The following is a description of a gene set: To obtain region- and disease-specific transcription profiles of human myocardial tissue, we explored mRNA expression from all four chambers of eight explanted failing, and five non-failing hearts using high-density oligonucleotide arrays (Affymetrix U95Av2). We performed pair-wise comparisons of gene expression in the categories (1) atria versus ventricles, (2) disease-regulated genes in atria and (3) disease-regulated genes in ventricles. In the 51 heart samples examined, genes showed divergent distribution between atria and ventricles (genes with higher expression in atria, genes with higher expression in ventricles). Two hundred and eighty-eight genes were differentially expressed in failing myocardium compared to non-failing hearts (genes regulated in atria and ventricles, 172 regulated in atria only, genes regulated in ventricles only). For disease-regulated genes, down-regulation was 4.5-times more common than up-regulation. Functional classification according to Gene Ontology identified specific biological patterns for differentially expressed genes. Eleven genes were validated by RT-PCR showing a good correlation with the microarray data. Our goal was to determine a gene expression fingerprint of the heart, accounting for region- and disease-specific aspects. Recognizing common gene expression patterns in heart failure will significantly contribute to the understanding of heart failure and may eventually lead to the development of pathway-specific therapies. Human Gene Set: KAAB_HEART_ATRIUM_VS_VENTRICLE_UP Genes up-regulated in the atria of healthy hearts, compared to venticles. from publication Kääb S, Barth AS, Margerie D, Dugas M, Gebauer M, Zwermann L, Merk S, Pfeufer A, Steinmeyer K, Bleich M, Kreuzer E, Steinbeck G, Näbauer M (PMID 15103417) studied in species Homo sapiens, and this is the list of marker genes: AGTR1, TRIP6, TIMP3, PTH1R, GRIN2C, ALDH1A2 (NCBI Gene Id 8854), PTGIS, SRSF8, ATM, CDC123, GJA5, EDNRA, NUPR1, ALOX12, TGFB1I1, MAP1B, VCAN, PLA2G2A, TBX5, FBLN2, QSOX1, PIP4K2B, EEF1A1, CHGB, FRMD4B, TUBB2A, ZNF271P, CD81, CSRP1, RALYL, LILRA4, ROR2, PRSS23, MYH6, DDR1, GRB2, ADORA1, CDK14, FGL2, DYRK2, NRTN, FEV, AKR1A1, KCNK1, VSNL1, MDK, MICAL2, POLD4, NALF2, PAM, TGFBR3, GPRASP1, CACNA2D2, EZH2, FGFR2, ARB2A, ERBB4, PLP1, AFAP1, EPHB2, MYBPC1, CALR, HEG1, EPS8, NDRG1 (N-myc downstream regulated 1), PBXIP1, FLRT2, LSM12, AEBP1, SOD3, EPB41L3, KHSRP, SMARCD2, SLC39A8, MAL, RELN, EPB41L1, NR2F2, ETV5, PRUNE2, MYLK, MYL6, ID4, RTN4, RPSA, NMNAT2, BTG1, CACNA1B, OS9, ADM, EXOSC2, RAB33A, GNB5, AGPAT1, CCN2, NME2, VASH1, F10, SURF2, DSC1, RPL3, BASP1, STAT4 (NCBI Gene Id 6775), SPOCK1, NUCB1, SMAD7, TAGLN, CD63, ME1, CD47, ID2, PTOV1, EPHA4, CDO1, RARRES2, XYLT1, CRIP1, MYL7, CPE, SLIT3, KCNJ3, CHRNE, PRELP, CHL1, ACTA2, PLK1, TGFB1, INPP1, RABGAP1L, LRRN3, CREB3L2, KCNK3, SLC9A1, UNC5B, S100A13, MYL4, MAGED2, KAZN, VAMP5, KCTD17, FMOD, FAM114A1, CYB561D2, PDE8B, MIPEP, RPS2, NSF, C1R (NCBI Gene Id 791254), SGCE, CELSR2, PLXNB2, MAGED1, KDELR2, PPIB, ITSN1, COL2A1, HYOU1, PLOD3, TMEM106C, ZFP36L2, CITED1, NR2F1, ABCC8, FEZ1, PRAF2, IL1RL1, TPGS2, CCDC85B (coiled-coil domain containing 85B), SLC22A18, NOMO1 (NODAL modulator 1), RBP1, PRDX1, TOR1A, BAD, SAT1, SLN, ERGIC3, WASHC2C, MGAT5, DAP, ACTN1, DAPK2, CFH, GRN, ENO2, DESI1, CHRDL1, STAT5B, ZNF365, PLCB1, MR1, SYNPO, PLA2G5, AUTS2, CADPS, GNAO1, NPPA, SERPINB8, BAMBI, CTSF, DPYSL3, TNK2, VAT1, ERBB2, BTG3, CCN5, EFEMP1, TSPAN7, NPPB, TAGLN2, AKR1C1, PARM1, ASXL1, TULP3, IGFBP6, USP11, CCL14, TRPC1, NTRK2, TNFSF13, NR0B2, PDE4B, SLC11A2, PML, TMED3, MYH11, SFRP1, KCNA5, NEB, GSE1, NAP1L1, DHODH, CIB2, DPT, ZNF208, JADE2, GPX3, GAS1, DDR2, PRKCD, RABAC1, ARHGAP1, TRAC, HSPG2, GABRB3, PDE2A, NUMA1, COMP, FBLN1 (NCBI Gene Id 2192), PDLIM4, VIM, COL4A6, IL1R1, SND1, ISLR, FRRS1L